Given this list of marker genes Atr, App, Ston2, Sv2a, Rab14, Septin6, Slc2a13 (NCBI Gene Id 239606), Cops5, Syn1, Disc1, Slc35f1, Atp6v1h, Ap3m2, Tafa4, Gabbr1, Sv2b, Rab5a, Kcnk9, Vti1b, Phaf1 (phagosome assembly factor 1), Vps33b, Rab3c, Rnf112, Sytl1, Vdac3, Bace1, Slc18a1, Hspa8, Rab8b, Atp6v0d1, Sec22b, Slc32a1, Dmxl2, Atp6v0a1, Entpd1, Btbd8, Gria2, Abcc8, Iqsec1, Rph3a, Sema4c, Tmed9, Rab27b, Rab5c, Clta, Syngr2, Lamp1, Lamp5, Syp, Rab6a, Atm, Atp6v0e2 (NCBI Gene Id 76252), Ddc, Rab26, Tor1a, Vps45, Rab7, Madd, Sgta, Vdac1, Rab35, Atp6v1e1 (ATPase, H+ transporting, lysosomal V1 subunit E1), Prrt2, Ptpn5, Ptprn, Slc5a7 (NCBI Gene Id 63993), Syt13, Unc13b, Penk, Bsn, Stxbp5, Atp6v1c1, Slc6a9, Cyp19a1 (NCBI Gene Id 13075), Exoc4, Amph, Sh3gl2, Otof, Ppfia2, Ica1, Arpc2, Atg9a, Sphk1, Ube3a, Slc10a4, Mt3, Prkn, Cops4, Kif3c, Pick1, Trim9, Scamp1, Clcn4, Cadps2, Vti1a, Clcn5, Rab11b, Ptprs, Znrf1, Slc17a8, Oprk1, Ap2m1, Wdr7, Septin5, Sytl5, Atp6ap1, Syt12, Ntf3, Ap2a1, Ndel1, Bdnf, Syt11, Sypl2, Slc30a3, Slc17a7, Clcn3 (chloride channel, voltage-sensitive 3), Kirrel3, Slc9b2, Syt4, Snca, Rab4b, Adam10, Lgi3, Sytl3, Atp8a1, Mtmr2, Rab8a, Unc13d, Slc18a3, Septin4, Cln3, Slc6a2, Cttnbp2, Vamp2, Slc17a5, Aph1a, Slc6a7, Cltc, Shh, Slc2a3, Brsk1, Atp6v1f, Septin1, Atp6v1b2 (ATPase, H+ transporting, lysosomal V1 subunit B2), Cadm1, Th, Nkd2, Rab13, Snap91, Syngr1, Prrt1, Hap1, Ap3s2, Rac1, Unc13a, Syt9, Syt10, Cplx3, Rab12, Kcnc4, Snap29, Doc2b, Trappc4, Dbi, Rab40b, Mme, Rab3a, Atp6v1g2, Synpr, Rab5b, Ncstn, Stx7, Rogdi, Slc2a8, Erc1, Pde4b, Apc, Mylk2, Doc2a, Sh3glb1, Kif1a, Trpm7, Syt5, Syn2, Vamp3, Dlg4, Vamp1, Tmem230, Syt17, Slc18b1 (solute carrier family 18, subfamily B, member 1), Ngf, Cbarp, Atp2b1, Slc35d3, Vdac2, Mff, Syt6, Sv2c, Gipc1, Mctp1, Anp32e, Calm3, Syndig1, Syngr3, Stx1a, Rabac1, Slc17a6, Slc6a17, Cltb, Cdk16, Rab2a, Gabra2, Park7, Dnajc5, Npy1r, Aqp2, Syt1, Bcl2l1, Atp6v1a, Atp6v0c, Gad2, Dnm1l, Dmd, Rab40c, Wfs1, Septin8, Tprg1l, Grin1, Slc22a2, Dlg2, Grin2a (NCBI Gene Id 14811), Rab4a, Atp6v1d, Sytl2, Snapin, Syn3, Pi4k2a, Ptprn2, Myo5a, Bin1, Sptbn2, Igf1, Anxa5, Syngr4, Slc4a8, Unc13c, Lrrk2, Kif1b, Tmem163, Phf24, Atp6v1g3, Stx6, Scamp5, Syt8, Rab10, Ap2a2, Marcksl1, Dgki, Atp6v1b1, Oprd1, Mctp2, Syt2, Snap25, Dlg1, Calm2, Svop, Ntf5 (neurotrophin 5), Gpr151, Grin2b, Gria1, Pebp1, Rab3d, Atp6ap2, Mal2, Ppt1, Dnm1, Stx12, Htr7, Sypl1, Syt15, Stx16, Dpysl3, Akap7, Slc35g2, Slc40a1, Atp6v1g1, Pdyn, Picalm, Calm1, Psen1, Atp6v0a4, Rab27a, Syt3, Sytl4, Psen2, Ston1, Rab3b, Drd2, Slc18a2, Borcs5, Ap1b1, Syt7, Dtnbp1, here is a description of the gene set: A transport vesicle that mediates transport from an intracellular compartment to the plasma membrane, and fuses with the plasma membrane to release various cargo molecules, such as proteins or hormones, by exocytosis. Mouse Gene Set: GOCC_EXOCYTIC_VESICLE studied in species Mus musculus